The following is a description of a gene set: studied in species Homo sapiens Human Gene Set: MIR6751_3P from publication Chen Y, Wang X (PMID 31504780) Genes predicted to be targets of miRBase v22 microRNA hsa-miR-6751-3p in miRDB v6.0 with MirTarget v4 prediction scores > 80 (high confidence targets)., and this is the list of marker genes: GAPT, PKNOX1, RAB6B, MPIG6B, GLRX, PPARGC1B, ST6GALNAC1, PTBP2, TMED7, BTBD7, RPS6KL1, EIF3CL, TP63, CD22, HTR1A, NAA60, OLA1, NAV1, MBD6, FAM98A, CCL22, KANK4, VKORC1, FMNL2, GCSAM, STX6, FNIP1, RRP8, SYNC, NAP1L5, SH2D2A, CPN2, ARMH3, B3GALT5, PIP5K1C, GLO1, N4BP3, MARK2, TP53INP2, SNX22, CHD3, ERCC4, MAPK1 (mitogen-activated protein kinase 1), AOPEP, TANC2, FBRS, WDR6, ISG20L2, MTF1, MTMR4, KRBA1, ANKRD13B, USP46, NLRP2B, PAX7, SOX5, CEMIP, ATF3, DAGLA, ZNF395, DYNAP, GNAO1, SET, PPIA, APOL6, EIF3C, GNAT1, NKIRAS2, HIC2, LRRC17, FYB2, SLC7A6, ZNF512B, SLC25A42, PITPNM3 (PITPNM family member 3), HID1, TREML2, NFATC3, ELK4, CARNMT1, ITGA8